The following is a description of a gene set: studied in species Homo sapiens Human Gene Set: MORF_PDPK1 Neighborhood of PDPK1 Neighborhood of PDPK1 3-phosphoinositide dependent protein kinase-1 in the MORF expression compendium, and this is the list of marker genes: LYZL6, USP11, ACR, UBE3B, CNTN1, DRG2, CAMK2B, NR1H2, CNOT4, RAP1GAP, RXRB, IGHMBP2, GIGYF2, NHERF2, CACTIN, RAP1GAP2, BCL3, TSPO2, CASP2 (NCBI Gene Id 835), LGALS9, GRK2, VAMP1, ANKRD12, PCBP3, GPR161, EFNA3, PHIP, NUDT3, MVK, GNL1, GPA33, PIM1, GSK3A, TPMT, GPR35, PRPH, KIF21B, FZR1, GRM4, SLC12A4, IGSF9B, IVD, PDPK1, ODF1 (NCBI Gene Id 4956), ZBED1, PNMT, HTR2A, SNW1, XRCC2, ALPG, GHITM (growth hormone inducible transmembrane protein), ZFPL1, PLEKHG3, GPRIN2 (NCBI Gene Id 9721), HSF4, CNPPD1, ZNF337, PFKFB2, CPNE6, PTGER3, E2F1, M6PR, LMTK2, KAT7, APOBEC3C, ARAF, CEACAM3, GP2, TRA2A (transformer 2 alpha homolog, NCBI Gene Id 29896), GTF2F1, KHNYN (NCBI Gene Id 23351), TUB, KIF1C, ARVCF